Given this list of marker genes MALT1, FGA, SOST, TPI1, IL6ST, PSMB8, COX8A, PEX2, FGB, MDFIC, MFSD2A, GFAP, SATB1, MADD (NCBI Gene Id 8567), ERCC4, FHL1, SLC25A22, DSP, PET100, OAS1, ACTN2, FGG (fibrinogen gamma chain), EXOC8, here is a description of the gene set: Death in adolescence species: Homo sapiens Death during adolescence, the period between childhood and adulthood (roughly between the ages of 10 and 16 years). Human Gene Set: HP_DEATH_IN_ADOLESCENCE